Given this list of marker genes Gsg1l, Rap2a, Eps8, Lgi1, Gpsm2, Ogt, Ap3m1, Igsf11 (immunoglobulin superfamily, member 11), Clstn1, Dnm3, Vamp2, Rdx, Adam22, Pip5k1c (phosphatidylinositol-4-phosphate 5-kinase, type 1 gamma), Als2, Rapsn, Magi2, Stx3, Rap1a, Mylk, Git1, Ppfia1, Cacng2, Dag1, Tamalin, Ap2a2, Gabarap, Hras, Clptm1, Tspan7, Lhfpl4, Dlg4, Gsk3b, Nbea, Snx6, Flot2, Caly, Dok7, Hip1 (NCBI Gene Id 77099), Camk2a, Itgb1, Lrp1, Cacng4, Nsg1, Zdhhc5, Drd4, Nedd4, Olfm2, Ctnnd1, Snx27, Rnf216, Tmem108, Vps35, Rnf220, Cntnap2, Nedd4l, Hpca, Sirt2, Syt3, Ophn1, Dlg2, Shisa6, Cacng8, Arc, Snap23 (synaptosomal-associated protein 23), Ctnnd2, Neto2, Ghsr, Efnb2, Gpc6, Grip1, Rala, Epb41l1, Adam10, C1ql3, Rab11fip5, Numb, Sh3glb2, Grid1, Cacng5, Rapgef4, Gphn, Agrn, Kif21b, Map2k1, Cacna2d2, Sst, Nptx1, Lpar1, Prkcz, Ppp3r1, Pacsin1 (NCBI Gene Id 353072), Stx4a, Iqsec2, Drd3 (dopamine receptor D3), Akap5, Porcn (porcupine O-acyltransferase), Grip2, Arhgap44, Drd5, Stx12, Grid2ip (glutamate receptor, ionotropic, delta 2 (Grid2) interacting protein 1), Rab11a, Atg5, Cpt1c, Myo6, Itgb3, Nptx2, Erbb4, Mdm2, Cblb, Ncdn, Ap2a1, Erbin, Cnih3, Hsp90aa1, Iqsec1, Hap1, Dlg3 (NCBI Gene Id 53310), Syt17, Vwc2 (von Willebrand factor C domain containing 2), Scrib, Prkn, Inpp4a, Snap47, Eps15, Zdhhc2, Shroom4 (shroom family member 4), Kalrn (NCBI Gene Id 72378), Ywhae, Gripap1, Ap2s1, Slc9a6, Rabep1, Mapk10, Vps26b, Gpc4, Cplx1 (NCBI Gene Id 12889), Frrs1l, Rab8a, Traf6, Prkci, Atad1, Nrg1, Neto1, Kif2c (NCBI Gene Id 73804), Nsg2, Grid2, Synj1, Sacm1l, Nrxn3, Slc12a5, Stx1b, Cacng3, Erbb2, Dlg1, Susd4, Cacng7, Musk, Ap2b1, Pick1, Tnik, Lrrc7, Tfrc, Nptxr, Usp46, Ap2m1 (adaptor-related protein complex 2, mu 1 subunit), Vac14, C1ql2, here is a description of the gene set: studied in species Mus musculus Mouse Gene Set: GOBP_REGULATION_OF_POSTSYNAPTIC_MEMBRANE_NEUROTRANSMITTER_RECEPTOR_LEVELS Any process that regulates the the local concentration of neurotransmitter receptor at the postsynaptic membrane.